Given this list of marker genes Prf1, Srgn, Gsdme, Gzmn, Gzmb, Nkg7, Lamp1, Gzmc, Ube4b, Bnip3, Gzmk, Fcgr4, Gzma, here is a description of the gene set: The series of molecular signals induced by granzymes which triggers the cell death of a cell. The pathway starts with reception of a granzyme signal, and ends when the execution phase of cell death is triggered. Granzymes are serine proteases that are secreted by cytotoxic T cells and natural killer cells to induce cell death in target cells. species: Mus musculus Mouse Gene Set: GOBP_GRANZYME_MEDIATED_PROGRAMMED_CELL_DEATH_SIGNALING_PATHWAY